Given this list of marker genes CFTR, AMTN, SLC4A2, TGFB1, ENAM, ODAPH, MMP20, DMP1, here is a description of the gene set: studied in species Homo sapiens Any process that modulates the frequency, rate or extent of enamel mineralization, the deposition of calcium salts in tooth enamel. Human Gene Set: GOBP_REGULATION_OF_ENAMEL_MINERALIZATION